The following is a description of a gene set: G13 signaling studied in species Homo sapiens Human Gene Set: WP_G13_SIGNALING, and this is the list of marker genes: SH3RF1, ARHGEF1, ARHGDIB, MAP3K4, LIMK1, IQGAP1, PIK3CD, RTKN, ARHGDIG, DIAPH1, WASL, MYL1, IQGAP2, RAC1, CFL2, CIT, PFN1, PPP1CB, CFL1, TNK2, RPS6KB1, WAS, RHPN2, CYFIP1 (NCBI Gene Id 23191), PIK3CA, CDC42, CALM1, PIK3CB, PIP4K2A, PAK3, RHOA, PKN1, MYBPH, MAPK10, ROCK2, PIK3R2, GNA13, ROCK1